The following is a description of a gene set: The chemical reactions and pathways resulting in the breakdown of a polyol, any alcohol containing three or more hydroxyl groups attached to saturated carbon atoms. studied in species Mus musculus Mouse Gene Set: GOBP_POLYOL_CATABOLIC_PROCESS, and this is the list of marker genes: Nudt3, Gk5, Tpi1, Gk, Pten, Synj2, Tkfc, Gk2, Ntsr1, Miox, Gpd2, Sord